The following is a description of a gene set: species: Homo sapiens Any functional abnormality of a cardiac valve. Abnormal heart valve physiology Human Gene Set: HP_ABNORMAL_HEART_VALVE_PHYSIOLOGY, and this is the list of marker genes: KRAS, TWIST1, COX7B, GPR101, NEDD4L, TRIP13, DTNA, IFNGR1, RNF2, C4A, PKD1, ZNF341, COL5A2, MYLK, SOS2, LMNA, UBE2A, RAP1B, MYSM1 (Myb like, SWIRM and MPN domains 1), NONO, NEK8, ARL6, LRP4, ZNF699, DSP, CITED2, SKIC3, WT1, FLNA, LTBP1, UBAC2, XYLT1, ABCC6, MYH7, DZIP1, ADA2, NIPBL, BAG3, PCSK9, ALG9, ARSB (arylsulfatase B), SON, WNT4, DAW1, PTPN11, CCDC32, GTF2I, RTEL1, RPS19, RPS6KA3, LMOD2, HAAO, MEGF8, FOXE3, ZMPSTE24, PARN, ERMARD (ER membrane associated RNA degradation), CCND2 (cyclin D2), MYH6 (NCBI Gene Id 4624), NEK1, OTUD5, XYLT2, COX6B1 (NCBI Gene Id 1340), SCN5A, IFIH1, TPM1, DVL3, TGFBR2, ARFGEF2, MYPN, DSE, VWF, KLRC4, DLL4, GDF1, GLA, ITPR1, COL5A1, SYT2, ZEB2, COL3A1, DPH1, PRDM5, TRAF7, ROBO4, NDUFB11, NF1, MAP2K2, TNNI3, TNNT2, ARSK, PPP1CB (protein phosphatase 1 catalytic subunit beta), TLR7, TBX2, ALDH18A1, MEFV, ENPP1, SPRED1 (sprouty related EVH1 domain containing 1), STRA6, CBL, CDC42, METTL27, BCOR, ZNF469, GTF2IRD1, ERI1, STX1A, SGO1, PLD1, PRG4, GATA5, SFTPC, CRYAB, B3GALT6, ACAD8, LEMD2, FGFR1, ESAM, PYROXD1, ODAD1, COL1A1, MAN2B1, WAC, PDSS1, ABCG5, RAF1, SLC25A24, HRAS, DNMT3A, NR2F2, GNPTG, RIGI, NKAP (NCBI Gene Id 79576), FBN2, BUB1B, ARF1, NKX2-5, GJA8, VPS37D, RAD21, LOX, TGFBR1, TAFAZZIN, HCCS, ACTA2, SOX5, ATP6AP1, TLL1, ABCG8, IGFBP7 (insulin like growth factor binding protein 7), CEP57, DSG1, DOHH, NCAPG2, FKTN, HIVEP2 (HIVEP zinc finger 2), BANF1, GNPTAB, FBLN5, TAF2, ZNF148, SPEG (NCBI Gene Id 729871), FAT4, G6PC3, KCNH1, RIT1, CIC, B3GLCT (beta 3-glucosyltransferase), GBA1, CHD7, D2HGDH, ALPK3, FNIP1, SCN1B, TERC, RFC2, SLC2A10, SDHD, ATRX, MRAS, KIF20A, TBL2, FAM13A, IL10, NKX2-6, MAP2K1, HGD, ARHGAP31, MUC5B, NPHP3, AHDC1, MAPK1, SMAD6, GPC4, CREBBP (CREB binding protein), SMAD3, RMRP, ERAP1, BUB3, FAS, COL1A2, ADNP, CTCF (NCBI Gene Id 10664), SNIP1, PLXND1 (plexin D1), EHMT1, DNAJC30, SMC3 (structural maintenance of chromosomes 3), KDM6A, SLC29A3, PSMD12, TLR4, WASHC5, CDH2, WDR37, SKIC2, CCNQ, MYH11, GTF2IRD2 (GTF2I repeat domain containing 2), IFT56, IL6ST (interleukin 6 cytokine family signal transducer), KIFBP, LDLR, RRAS2, PRDM16, RPL3L, SARDH, IL12A-AS1, FKBP14, HLA-B, CCR1, GPC3, KANSL1, STN1, NOTCH1, SLC31A1, SOS1, POLR3A, CHD3, DCHS1, WBP4, FLI1, LIMK1 (NCBI Gene Id 3984), ANKS6, RAB23 (RAB23, member RAS oncogene family), CLIC2, IL12B, FHOD3, NEK9, ATP6V1E1, FKBP6, PRKAR1A (protein kinase cAMP-dependent type I regulatory subunit alpha), DPH2 (NCBI Gene Id 1802), PIK3R2 (NCBI Gene Id 5296), SKI, DPP9, SMAD4, FHL1, NRAS, BMP2, TTR, HEY2, ARPC4, ACTB, DOCK7, C12orf57, EFEMP2, SFTPA2, TBX1, ADAMTSL2 (NCBI Gene Id 9719), KMT2D, THSD1, AIP, EBP, MAP1B, TAB2, SMARCA4, BRAF, THSD4, POLG, GJA1, CRKL, IL12A, ANKRD11, NRXN1, TERT, GATA6, EP300, STAT4, GJA5, MCTP2, SHOC2, LRPPRC, ACTC1, ABCA3, DNAL1, DDX3X, CSGALNACT1, CIROP, ZIC3, TBCK (TBC1 domain containing kinase), SMC5, SFTPA1, APOB, MTX2, HCN4, MYCN, LZTR1, FBXW11, HADHA, YY1AP1, B4GALT7, AGA, PGAP1, TGFB3, COA6, MYL2, PCGF2, DYRK1A, AGO2, ADK, VPS33A, HEATR3, IRX5, IL23R, PUF60, TNNC2, FLT4, TMEM270, FOXF1, ADA, CUL3, CLIP2, INVS, KLHL24, CCDC22, GLB1, MAT2A, HEXB, TGFB2, SLC35A1, FLNC, ATP11A (NCBI Gene Id 84170), NOTCH2, FBN1, PPP1R13L, DPYSL5, ADAMTS10, BPTF (bromodomain PHD finger transcription factor), NCF1, TMTC3, RPL27, AGR2, RSPRY1, SLC22A5, TBX5, AMER1, HADHB, SCN4A (sodium voltage-gated channel alpha subunit 4), PEX2, BUB1, GNS, MGP, RPL5, ADAMTS17, KAT6A, TBX20, AKT3, MLX, BUD23, MFAP5, CHST14, LDLRAP1, PRKG1, VPS35L, SPTBN1, GATA4, EXOSC5, MLXIPL, SZT2, SPRED2, IDUA, BCR, SMAD2, ADAMTS19, HEPHL1, LTBP3, TWNK, LTBP2, ELN, BAZ1B, RNF135, EIF4H, CHST3, MAP3K7, TXNDC15